The following is a description of a gene set: Any process that stops, prevents or reduces the rate or extent of antiviral mechanisms, thereby facilitating viral replication. studied in species Homo sapiens Human Gene Set: GOBP_NEGATIVE_REGULATION_OF_DEFENSE_RESPONSE_TO_VIRUS, and this is the list of marker genes: RNF26, ATG5, MICB, ITCH, TRIM38, ILRUN, PCBP2, TARBP2, PPM1B, FOXP3, C1QBP (NCBI Gene Id 708), TRAF3IP1, MIR26B, MUL1 (NCBI Gene Id 79594), FGL2 (fibrinogen like 2), NT5C2, IRGM (NCBI Gene Id 345611), ATG12